Given this list of marker genes Epas1, Hesx1, Xlr4b, Plekha4, Rnf17 (ring finger protein 17), Enah, Zc3hav1, Ak7, Laptm5, Mylpf, Liph, Hsd17b14, Trap1a, Psma8, Fgf4, Ifitm1, Pfkp, Nanog, Mt1, Manba, Ass1, Spp1, Chac1, Sord, Hsf2bp, Fntb, AU018091, Sema4b, Fthl17e, Klhl13, Morc1, Tex19.1, Mybl2, Pnma5, Cdc5l, Jam2, Calcoco2, Trib3, Tet1, Cyp2s1, Itpr3, Gjb3, Gstp2, Bicral, Ulk1, Satb2, Tmem40, Upp1, Bclaf3, Mreg, AU015836, Klf2, Tm7sf3, Mtmr12, Rnf125, Gm2a, Rdm1, 8030474K03Rik, Eprn, Dnajc6, Msc, Npl, Lrrc2, Tbx3, Epop, Rhox5, Ly6g6e, Slc39a4, Tet2, AA467197, Impa2, Xlr3a, Znf41-ps, Esrrb, Tmem64, Nfatc2ip (NCBI Gene Id 52217), Fabp3-ps1, Ooep, Cobl, Khdc3, Aqp3, Mov10, Kmt2c, Tcl1, Slc25a20, Aldh6a1, Lncenc1, Nphs1, Usp9x, Tfpi, Tm9sf5, Slc29a1, Rpap1, H19, Otx2, Tex15, Zfp229, Pura, Gabarapl2, Tfcp2l1, Rpl39l, Rpp25, Prdm14, Fbxo15, Dnmt3l, Cyct, Hprt1, Rhox6, Acaa2, Ipmk, Cenpm, Wnk3, Lama1, Chchd10, Pck2, Zfp600, Fmr1nb, Htra1, Hdac6, Agtrap, Nr0b1, Aire, Phf11a, Klf4, here is a description of the gene set: from publication Pasini D, Bracken AP, Hansen JB, Capillo M, Helin K (PMID 17339329) Genes up-regulated in ES (embryonic stem cells) with defficient SUZ12. Mouse Gene Set: PASINI_SUZ12_TARGETS_UP Polycomb group (PcG) proteins form multiprotein complexes, called Polycomb repressive complexes (PRCs). PRC2 contains the PcG proteins EZH2, SUZ12, and EED and represses transcription through methylation of lysine (K) 27 of histone H3 (H3). Suz12 is essential for PRC2 activity and its inactivation results in early lethality of mouse embryos. Here, we demonstrate that Suz12(-/-) mouse embryonic stem (ES) cells can be established and expanded in tissue culture. The Suz12(-/-) ES cells are characterized by global loss of H3K27 trimethylation (H3K27me3) and higher expression levels of differentiation-specific genes. Moreover, Suz12(-/-) ES cells are impaired in proper differentiation, resulting in a lack of repression of ES cell markers as well as activation of differentiation-specific genes. Finally, we demonstrate that the PcGs are actively recruited to several genes during ES cell differentiation, which despite an increase in H3K27me3 levels is not always sufficient to prevent transcriptional activation. In summary, we demonstrate that Suz12 is required for the establishment of specific expression programs required for ES cell differentiation. Furthermore, we provide evidence that PcGs have different mechanisms to regulate transcription during cellular differentiation. species: Mus musculus